The following is a description of a gene set: Genes down-regulated in NK cells: primary versus activated and expanded. Human Gene Set: GSE12198_NK_VS_NK_ACT_EXPANSION_SYSTEM_DERIVED_NK_CELL_DN species: Homo sapiens from publication Fujisaki H, Kakuda H, Shimasaki N, Imai C, Ma J, Lockey T, Eldridge P, Leung WH, Campana D (PMID 19383914) Transcriptional profiling of NKAES-derived NK cells after 7 days of culture compared to primary human NK cells and NK cells stimulated by low or high dose IL2 after 7 days of culture., and this is the list of marker genes: ADAM8 (NCBI Gene Id 101), LTA, MICU1, HKDC1, TMEM33, TCEAL9, IGFBP7, ABHD4, UBE2M, SGK1, TRIM69, PDE6D, ALDH18A1, EBI3, HARS1, C15orf40, LSM3, RBMX, RALB, LUZP1, INTS7, HDLBP, ADAM10, RBMX2, IGF2BP3, CTSE, SLC7A4, KLC1, EHBP1L1, WEE1, CA13, ANKRD44, STX2, SLC44A2, RPUSD1 (NCBI Gene Id 64723), NQO2, RPA3, PITPNM1, CENPQ, RNF14, XYLT2, EEF1B2, RAN, YPEL5, MMD, EBF1, LAIR1, CSTB, TMEM109, ARHGDIA, MTHFR, RECQL, TSPAN2, INHA, PRSS16, RTN3, ARHGAP18, MYO6, TCF25, LRATD1, TTC39C, KDELR1, SLC22A1, TRPC4AP, SREBF2, EFCAB2, CENPO, EIF2B2, PNPLA2, CENPV, CAMK4, B4GALT4, CHEK2 (checkpoint kinase 2), PIGA, CFAP410, PEA15, PPP3CB, CLASP1, RIPOR1, CALCRL, PSMD9, MRPS23, CNIH1, PELI2, LGALS2, NUDT1 (nudix hydrolase 1), SCAF11, ULK2, SUCLG2, IL6R, PDLIM5, CNP, NIPSNAP1, CTNNBIP1, CST3, C15orf39, MORF4L2, PYCR2, BSG, TMIGD1, ARHGAP12 (NCBI Gene Id 94134), H2BC5, PTGR2, ARPC1A, CHFR, MPND, DAZAP1, MCM2, JMJD1C, CDC42SE1, LFNG, PUS10, XRCC2, CDKN2C, TUBD1, C16orf87, SOWAHC, TGFA, SIAE, H19 (H19, imprinted maternally expressed transcript), SEC61B, CARMIL1, IL7R, LMBR1, RAB14, PEX7, VAMP7, SPTBN1, HIBCH, NONO, CNIH3, GTF3C5, ETFDH, ACTR1A, BRDT, IDH2, HUS1, HABP4, NCKAP1, FUCA2, SERPINI1, CCDC25, SNAPC3, ABCG1, DEXI, ELOF1, OARD1, GLOD4, UBE2K, PLS3, HNRNPUL2, SLC2A1, ACD, NUDT13, NAAA, ZFAND2B, CTSB, GATM, ADIPOQ, ANAPC4 (anaphase promoting complex subunit 4), SLC66A1, C3orf38 (chromosome 3 open reading frame 38), CASKIN2, LDHA, KRTCAP2, SERINC3, NUDT5, SNX21, TMEM115, IFT74, HERC4, MBNL1, SLC2A8, CBR4, DCPS, POLE3, OR2S2, CIR1, PAICS, NRDE2, NASP, GNPDA1, MRPS34, FDPS, PGM1, METTL8, DCTN2 (dynactin subunit 2), PSEN1, CCDC117, ABHD17A, RCBTB1, ZC3H12C, EXTL2, SCCPDH, PIGP, GEMIN2, PTPN9 (protein tyrosine phosphatase non-receptor type 9), RANBP1, PTGER4, ZNF394